The following is a description of a gene set: Human Gene Set: GOBP_REGULATION_OF_CDC42_PROTEIN_SIGNAL_TRANSDUCTION studied in species Homo sapiens Any process that modulates the frequency, rate or extent of Cdc42 protein signal transduction., and this is the list of marker genes: TAX1BP3, NRP1 (NCBI Gene Id 8829), ABL1, CCR7, RIT2, ABCA1, CCL19, APOE, APOC3, RALBP1, APOA1, ARHGEF16